Given this list of marker genes CD302, ADA2, PPT1, NOD2, ARRB2, ACAP2, SELL, CFP, CCR1, CYBB, PTPRE, NCF2, TCIRG1, IGSF6, ITGB2, MNDA, CSGALNACT2, GMIP, AP1S2, RAB11FIP1, IFNGR1, OTULINL, CNPY3, AIF1, IER2, RGS2, EVI2B, NAIP, SKAP2, MFSD1, HSD17B11, PYCARD, PECAM1, THEMIS2, S100A4, CASP1, DAZAP2, DPEP2, STX11, PLCB2, FBXL5, FMNL1, MCL1, SAMHD1, CLEC4A, TLR8, TLR2, MYD88, HCK, USP3, LILRA1 (leukocyte immunoglobulin like receptor A1), LILRA6, PRKCD, CMTM6, CTSS, CHST15, JUNB, here is a description of the gene set: Human Gene Set: GNF2_MCL1 species: Homo sapiens Neighborhood of MCL1 myeloid cell leukemia sequence 1 (BCL2-related) in the GNF2 expression compendium Neighborhood of MCL1